Given this list of marker genes SPDEF, AGR2, ADAMTSL2, HOXA5, IL13, here is a description of the gene set: species: Homo sapiens Human Gene Set: GOBP_LOBAR_BRONCHUS_EPITHELIUM_DEVELOPMENT The biological process whose specific outcome is the progression of a lobar bronchus epithelium from an initial condition to its mature state. This process begins with the formation of the lobar bronchus epithelium and ends with the mature structure. The lobar bronchus epithelium is the tissue made up of epithelial cells that lines the inside of the lobar bronchus.